The following is a description of a gene set: The reproductive and endocrine functions of the ovary involve spatially defined interactions among specialized cell populations. Despite the ovary's importance in fertility and endocrine health, functional attributes of ovarian cells are largely uncharacterized. Here, we profiled >genes in 257 regions from the ovaries of two premenopausal donors to examine the functional units in the ovary. We also generated single-cell RNA sequencing data for 21,198 cells from three additional donors and identified four major cell types and four immune cell subtypes. Custom selection of sampling areas revealed distinct gene activities for oocytes, theca, and granulosa cells. These data contributed panels of oocyte-, theca-, and granulosa-specific genes, thus expanding the knowledge of molecular programs driving follicle development. Serial samples around oocytes and across the cortex and medulla uncovered previously unappreciated variation of hormone and extracellular matrix remodeling activities. This combined spatial and single-cell atlas serves as a resource for future studies of rare cells and pathological states in the ovary. from publication Jones ASK, Hannum DF, Machlin JH, Tan A, Ma Q, Ulrich ND, Shen YC, Ciarelli M, Padmanabhan V, Marsh EE, Hammoud S, Li JZ, Shikanov A (PMID 38578993) Human Gene Set: JONES_OVARY_OOCYTE species: Homo sapiens, and this is the list of marker genes: TDRD1, PADI6, SAP18, PROSER1, NLRP4, H1-1, H2BC12L, OSBPL10, THYN1, NLRP13 (NCBI Gene Id 126204), ITGA4, NTN1, GYG1, OOSP2, NLRP5, CDK7, HSP90AA1, DPPA3, WEE2, STK24, ADAP1, ERO1B (endoplasmic reticulum oxidoreductase 1 beta), ESRP1, ACTL8, SMS, BRI3, PFDN2, H2AC19, SYTL3, RGS2, DCDC2, NLRP9, EZR, JAZF1, ZAR1, H2BC1, REC114, RALB, FIGLA, CDCA7L, WFDC2, TRAF2, NDE1, UPB1, ESCO2 (establishment of sister chromatid cohesion N-acetyltransferase 2), ZP3, GPM6B, PAIP1, ZP4, OR2T35, NLRP2, EIF4ENIF1, PFKP, TUBB8 (NCBI Gene Id 347688), CTRB2, UCHL1, UHRF1, OR2T27 (olfactory receptor family 2 subfamily T member 27), DLGAP5 (DLG associated protein 5), KPNA7, PDCD5, LHX8, BAIAP2L1, ODC1, UBB, SHD, DNAJA1, EPCAM, TKTL1, GDI2, ZFAND2A, BPGM (NCBI Gene Id 669), C6orf52, FOXR1, NCK2, FDFT1